Given this list of marker genes Jakmip1, Pcbp4, Tmem100, Pi4k2a, Trf, Cacna1h, Pdzd2, Gfod1, Klrd1, Rfc3, Slx1b, 4933404O12Rik, Smurf1, Slc15a2, Rab19, Slc11a2, Kremen1, Osr2, Riok3, Pyurf, Hipk2, Dusp3, Rgs18, Gpsm1, Irgm2, Asb10, Ift22, Kbtbd2, Zw10, Msh5, Lancl1, Kantr, Abhd14a, Tecpr1, Arvcf, Tspan2, Ccbe1, Rasgrp3, H2-Ea (NCBI Gene Id 14968), Avl9, Scn8a, Asph, Crlf1, Naglu, Gimap3, Abca1, Sult1a1, Zfp974, 2010109A12Rik, Rnf122, 6820402A03Rik, Gm15337, 2610507I01Rik, Slpi, Snx10, Cenpa, Rpap2, Imp4, Nav2, Lifr, Eif2s1, Gm37254, Hvcn1, Fundc2, Trim12a, Clec2i, here is a description of the gene set: from publication Bredemeyer AL, Helmink BA, Innes CL, Calderon B, McGinnis LM, Mahowald GK, Gapud EJ, Walker LM, Collins JB, Weaver BK, Mandik-Nayak L, Schreiber RD, Allen PM, May MJ, Paules RS, Bassing CH, Sleckman BP (PMID 18849970) DNA double-strand breaks are generated by genotoxic agents and by cellular endonucleases as intermediates of several important physiological processes. The cellular response to genotoxic DNA breaks includes the activation of transcriptional programs known primarily to regulate cell-cycle checkpoints and cell survival. DNA double-strand breaks are generated in all developing lymphocytes during the assembly of antigen receptor genes, a process that is essential for normal lymphocyte development. Here we show that in murine lymphocytes these physiological DNA breaks activate a broad transcriptional program. This program transcends the canonical DNA double-strand break response and includes many genes that regulate diverse cellular processes important for lymphocyte development. Moreover, the expression of several of these genes is regulated similarly in response to genotoxic DNA damage. Thus, physiological DNA double-strand breaks provide cues that can regulate cell-type-specific processes not directly involved in maintaining the integrity of the genome, and genotoxic DNA breaks could disrupt normal cellular functions by corrupting these processes. species: Mus musculus Mouse Gene Set: BREDEMEYER_RAG_SIGNALING_NOT_VIA_ATM_DN Genes down-regulated in pre B lymphocyte after induction of physiological DNA double-strand breaks (DSB) by RAG2; the changes are independent of ATM signaling.